Given this list of marker genes FIG4, HCCS, GTPBP3, SGCG, PLEKHG5 (NCBI Gene Id 57449), VAPB, PMP22, SLC12A5, AKT3, EXT2 (NCBI Gene Id 2132), RASA1, TICAM1, PNPLA2 (patatin like phospholipase domain containing 2), PRF1, SMS (spermine synthase), FHL1, MT-TE, YARS1, VDR, LMNB1, COL12A1, TBCE, SLC25A4, RYR3, FKTN, FRG1, POMGNT1, SLC25A1, PEX1, RAD51, PIGA, ANO5, SNUPN (NCBI Gene Id 10073), NTNG1, CRPPA, DOK7, GAA, LIG3, COX7B, TNPO3, PLP1, RTN2, DAB1, SYT2, MEGF10, GIGYF2, TGFB1, GDAP2, ARG1, SURF1, POMK, MT-ATP6, TWNK, UNC13D, MTMR14, DNA2, GRID2, UBE3A, TBC1D24, HACD1, JPH3, SGCD, GALC, ALG14 (ALG14 UDP-N-acetylglucosaminyltransferase subunit), NEB, SCN4A, ASPA, OPA1, POMT2, ERCC8, PLEC, MYO9A, TAF1, NDUFB11, BICD2, MAPT, CASQ1, ADAR, SPEG, NUP54, VPS13D, COL6A2, BAG3, TRAF3, FKBP14, MFN2, STX11, CYP2R1, DPAGT1, PFKM, CHRNA1 (NCBI Gene Id 1134), CDH23, KCNC3, VMA21, TLR3, MYPN, SCO2, DNMT3B, TK2 (NCBI Gene Id 7084), KBTBD13, GRIN2A, ACTA1, LRP12, BAP1, SGCA, NUP62, SUFU, MIEF2, STXBP2, COL6A3, PMP2, COQ2, SMO (smoothened, frizzled class receptor), TYMP, RNF170, PHKG1, GPHN, TET2, MPZ, VPS35, VCP, MPL, NOL3, VAMP1, SDHAF1, TFG, DNM2, SELENOI, NFE2L2, ADCY5, CACNA1A, TRAF7, CYP27B1, DNAL4, DAG1, FAR1, WARS2, SCN1A, DUX4L1, SMCHD1, CHAT, WDR62, LMNB2, FKRP, JAK2, PANK2, MFF, CDKL5, BRCC3, MEN1, LRRK2, BSCL2, NTRK1, SDHB, RETREG1, SLC18A3, VWA1, RYR1, TTN, PIK3R5, CCN6 (cellular communication network factor 6), NUDT2 (nudix hydrolase 2), GMPPB, NEFL, MTOR, DYSF, ISCU, GJB1, GFPT1, PDGFB, RRM2B, TPM2, MAP3K20, CCDC78, MICU1, PHKA1, ADSS1, LIPE, SCN2A, CALR, PYROXD1, ATP2B3, KCNQ2, POLR3B, NF2, NEFH, ABCD1, MYH7, ARHGEF2, REEP2, MYOT, OCA2, TMEM126B, GLRA1, TERT, BIN1, AGRN, PI4KA, CFL2, ATP13A3, MUSK, COL6A1, MECP2, GOSR2, DNAJC13, CLN8, RNU12, CHST11, PDE10A, AGK, GRM1 (NCBI Gene Id 2911), SLC19A3, NTN1, LAMB2, TRMT5, TCAP, SLC5A7, REEP1, POLG2, LDHA, ITPR1, SMG9 (SMG9 nonsense mediated mRNA decay factor), LRIF1, SLC34A3, SMARCB1, ATP2A1, HADHA, CAPN3, ITGA7, PRNP, CHRND, SLC25A42, DYNC1H1, SDHA, SNAP25, ASAH1, RPL10, RNASEH1, AK9, ABCC8, COL13A1, LAMA2, SPR, NDUFA1, COLQ, GPAA1, SCYL1, TOR1AIP1, NFU1, KCNT1, SPTAN1, SH3TC2, GABBR2, ALG2 (NCBI Gene Id 85365), KY, DLAT, KIF1C, LRP4, CHRNB1, PEX2, LMNA, FA2H, MRE11, FBXO38, CHRNE, HSPB3, EPHB4, GDAP1, HINT1, DYM, UNC93B1, HNRNPK, CCDC88C, SMC1A, ALAD, COX20, ERCC6, CHP1, HADHB, NDRG1 (N-myc downstream regulated 1), SDHD, SNCA, MTPAP, SLC25A22, PLCB1, DCC, PRKAR1A, EXT1, ATL1 (NCBI Gene Id 6681), VPS13A, PEX16, RAPSN, TDP2, B4GALNT1, POMT1, TPM3, AKT1, SMARCE1, FLNC, ARSA, DNAJB6, MYL2, TBK1, MGME1, NKX2-1, SFXN4, DMD (dystrophin), EIF4G1, DUX4, GBA1, SLC12A6, PIK3CA, POPDC3, TNNT1, NARS2, MORC2, AIP, STIM1, SELENON, PSAP, ATP6AP2, SPAST, POLG, CWF19L1, SPTLC1, here is a description of the gene set: Functional motor deficit Human Gene Set: HP_FUNCTIONAL_MOTOR_DEFICIT studied in species Homo sapiens